The following is a description of a gene set: Mouse Gene Set: WP_ONECARBON_METABOLISM One-carbon metabolism studied in species Mus musculus, and this is the list of marker genes: Dhfr, Mtrr, Ftcd, Mthfs (5, 10-methenyltetrahydrofolate synthetase), Ahcy, Mtfmt (NCBI Gene Id 69606), Dnmt3a, Shmt1 (serine hydroxymethyltransferase 1 (soluble)), Ehmt1, Mthfd1l, Dnmt1, Tcn2, Atic, Ahcyl2, Mtr, Shmt2, Mthfr, Tyms, Mthfd2, Ehmt2, Mat2b, Bhmt, Aldh1l1, Mthfd1, Amt, Dnmt3b, Gart, Folh1 (NCBI Gene Id 53320), Mat1a